Given this list of marker genes HLA-G, MIR424, FOXO4, PPP2R5B, CHEK1, ZNHIT1, DUX4, MIR503, DAB2IP, here is a description of the gene set: Human Gene Set: GOBP_NEGATIVE_REGULATION_OF_G0_TO_G1_TRANSITION studied in species Homo sapiens A cell cycle process that stops, prevents, or reduces the rate or extent of the transition from the G0 quiescent state to the G1 phase.